The following is a description of a gene set: Painful sensations elicited by a nonpainful cutaneous stimulus such as a light touch or gentle stroking over affected areas of the body. Sometimes referred to as hyperpathia or hyperalgesia. Often perceived as an intense burning, dyesthesias may outlast the stimulus by several seconds. species: Homo sapiens Dysesthesia Human Gene Set: HP_DYSESTHESIA, and this is the list of marker genes: ALDH4A1, DKK1, PMP22, SCN10A, RNF170, SCN11A, ZFTA, FMR1, ABCD1, GRIN2A, SPTLC2, CHST14, SDHA, SCN9A, NLRP3, PRNP, SRPX2, PEX16, DSE, GABRG2, NKX6-2